The following is a description of a gene set: The process in which a folic acid, or one of its derivatives (dihydrofolate, tetrahydrofolate, methylene-tetrahydrofolate or methyl-tetrahydrofolate) is transported across a membrane. species: Mus musculus Mouse Gene Set: GOBP_FOLATE_TRANSMEMBRANE_TRANSPORT, and this is the list of marker genes: Slc19a1, Slc25a32, Abcc5, Lrp2, Slc46a1